The following is a description of a gene set: Genes down-regulated in comparison of dendritic cells (DC) stimulated with LPS (TLR4 agonist) at 6 h versus DC cells stimulated with Pam3Csk4 (TLR1/2 agonist) at 6 h. from publication Amit I, Garber M, Chevrier N, Leite AP, Donner Y, Eisenhaure T, Guttman M, Grenier JK, Li W, Zuk O, Schubert LA, Birditt B, Shay T, Goren A, Zhang X, Smith Z, Deering R, McDonald RC, Cabili M, Bernstein BE, Rinn JL, Meissner A, Root DE, Hacohen N, Regev A (PMID 19729616) Human Gene Set: GSE17721_LPS_VS_PAM3CSK4_6H_BMDC_DN mouse primary BMDCs were stimulated with tlr ligands and gene expression changes were profiled on Affymetrix arrays studied in species Homo sapiens, and this is the list of marker genes: CNOT9, SEC31A, FANCE, UQCRHL, ATP2A2, DENND10, ASCC2, PIM3, NCAPH2, KLHDC3, ATG5, MBTD1, FAM20C, RPS11, ADGRD1, STAB1, DHX16 (DEAH-box helicase 16), LPIN1 (NCBI Gene Id 23175), LAPTM5, HVCN1, ZNF830, HNRNPU, SMARCD2, IMPDH2, HSPA4 (heat shock protein family A (Hsp70) member 4), SAA1, TMEM184C, LSM3 (LSM3 homolog, U6 small nuclear RNA and mRNA degradation associated), FAM118A, CIDEA, KCTD12, HYCC2, EFTUD2, SPIC, TMEM214, SEC61B, RCAN1, MPV17, SLAIN2, CUTA, CD14, AHCYL1, PSEN2, GDAP2, GPR155, TRAPPC1, SYK, THUMPD3, POLR3D, AFG1L, ODR4, SLC39A9, RAC2, GOSR2, CDCA5, GTF2H1, PYCR2, ORMDL1 (ORMDL sphingolipid biosynthesis regulator 1), LRRC58, LMAN2, BCL7B, TOB2, CSF1R, FAM162A, YBX1 (NCBI Gene Id 7806, Y-box binding protein 1), TMEM87A, GALE, NECAP2, UTP20, AIFM1, TMEM199, PNO1 (NCBI Gene Id 80711), DYM, PRMT3 (NCBI Gene Id 10196), ZC3H8, ARSA, CIAO1, CCT3, MORF4L1, TP53RK, SEC22B, UBE2E2, FTL, RRN3, MFN2, SLC25A19, LTV1, RNASEH2C, ZFP36L1, AGFG2, CALR, POLR2E, MYC, HELB, GARS1, RAD17, MRPL57, PWP2, ZNF326, BCCIP, BCAS2, MBD3, NOP2, RIC8A, PRKAG2, UBE2J1, DRG1, KPNB1, SUN1, PLA2G6, SLC17A9, PCCB, PSTPIP2, MICOS13, DNAJC5, EVI5, LAMTOR1, DYNLL1, WDR13, ADGRE5, HSCB, TMEM9B, MRPL20, POLR2I, QNG1, EIF3I, DDX39A (NCBI Gene Id 95781), MGST1, KCNAB2, HDGF, ZDHHC16, ZNF451, NIT1, PTPN23, MLLT10, HSPH1, TRPM8 (NCBI Gene Id 79054), BOLA1, EIF4B, CPEB1, MEFV, DYNLT3, MAP2K3, RAB31, PRKCH, HNRNPUL2, IVD (isovaleryl-CoA dehydrogenase), COX19, UBE2A, ACSS2, REXO2, CAMK1D, PRRG2 (proline rich and Gla domain 2), PIGH, PUS7, CRELD1, ARHGDIB, KPNA2, TYROBP, TRMT10C, ASNS, ACADVL, RNF187, MRPL28, HSD17B12, PPP2R3C, CTU1, IFRD2, ELAC2, POLR2A, TMEM14C, GRK6, CXCL6, MRPS14, TP53INP2, CORO1C, CTSA, PARP16, TLE6, AKR1B15, FLAD1, CEP20, NCF2, RPF2, PPBP, C12orf43, UBP1, CLEC6A, COPS5, RAG1, ATF1, RDH10, FNTA, TUBA1B, EEF1B2, TWF2, COQ9, CLNS1A, SOX18